Given this list of marker genes BSG (basigin (Ok blood group)), AQP2, TAT, SLC34A1, PARK7, MT-CYB, AQP1, ALAD, PGAM2, SLC39A8, SLC1A1, here is a description of the gene set: species: Homo sapiens Human Gene Set: GOBP_RESPONSE_TO_MERCURY_ION Any process that results in a change in state or activity of a cell or an organism (in terms of movement, secretion, enzyme production, gene expression, etc.) as a result of a mercury ion stimulus.